Given this list of marker genes Ghsr, Or4m1, Npy, Nr1h4, Ghrl, Fbn1, Oprm1, here is a description of the gene set: Any process that activates or increases the frequency, rate or extent of a response to nutrient levels. Mouse Gene Set: GOBP_POSITIVE_REGULATION_OF_RESPONSE_TO_NUTRIENT_LEVELS studied in species Mus musculus